The following is a description of a gene set: Any process that stops, prevents, or reduces the frequency, rate or extent of the activity of any activin receptor signaling pathway. Mouse Gene Set: GOBP_NEGATIVE_REGULATION_OF_ACTIVIN_RECEPTOR_SIGNALING_PATHWAY species: Mus musculus, and this is the list of marker genes: Fkbp1a, Igsf1, Fstl3, Cer1, Fst, Mir210, Dact2, Lefty1, Lemd3, Synj2bp, Magi2, Smad7, Ski, Dand5, Smad6, Acvr1, Smurf1